The following is a description of a gene set: Mouse Gene Set: chr3F1 studied in species Mus musculus, and this is the list of marker genes: Sh2d2a, Iqgap3, Snord73b, Insrr, Rusc1, Rhbg, Gatad2b, Fbxw7, Mif-ps3, Rps27, Sprr5, Mir7669 (NCBI Gene Id 102465771), Nes, Tsacc, Snord73a, Sprr2d, Lce1m, Gm23850, Bglap2, Thbs3, Gm24481, Gm27811, Sprr2e, Ivl, Gm37116, Gm22577, Adam15, Sprr2a1, Ubqln4, Smg5 (SMG5 nonsense mediated mRNA decay factor), Gm15998, Lce1g, Sprr2b, Gm9790, Lce6a, Pmvk, Gm5849, Pklr, Ints3, Sh3d19, Gm18403, Dpm3 (dolichyl-phosphate mannosyltransferase polypeptide 3), Sprr2a2, Gpatch4, Lrrc71 (leucine rich repeat containing 71), Rab25, Pglyrp3, Lce1d (late cornified envelope 1D), Krtcap2, Paqr6, 4930511M18Rik, 1700036G14Rik, Gm25820, Khdc4, Gm9023, Lelp1, Mnd1, Gm24403, Bcan, Lce1h, Crtc2, Zbtb7b, Isg20l2, S100a5, 1500004A13Rik, S100a1, Lce1b, Gm23464, Rit1, Cct3, Aqp10-ps, Mtx1, Gm3764, 4632404H12Rik, Crnn, Ubap2l, Entrep3, Gm5284, Loricrin (NCBI Gene Id 99536), Gm23376, Trim46, Ssr2, Mir3093, Lce1l, Mex3a, Gm10253, Lce1k, S100a4, Gm19739, Gm36981, Prr9, Fcrl1, Bglap3, Sprr2g, S100a7a, Sprr2h, AW047730, S100a9, Fhip1a, She, Sprr1a, Lce1e, Creb3l4, Gm21956, Gm23054 (NCBI Gene Id 115489857), Sema4a, Gm15535, 4930565D16Rik, Fdps, Adrm1b, Sprr2f, Pygo2, Gba1, Cd5l, Kplce, Pear1, Gm7166, Sprr2i, Mir1905, Slc50a1, Gm24185, Gm10705, Ash1l, Gatb, S100a7l2, Dclk2, Prcc, Gm5979, Lce1f, Flad1, Mir92b, Gm42579, Tmem154, Etv3l, Glmp, Hdgf, S100a2, Gm5850, Crct1, Mettl25b, Gm3788, Lce1a2 (NCBI Gene Id 73722), Arhgef2, Rpl13-ps4, S100a16, Prss48, Crabp2, S100a13, Slc27a3, Gm35439, Etv3, S100a6, Gm15417, Kcnn3, 2210017I01Rik, Slc39a1, Lce1j, Arhgef11, Mir7011, Ilf2, Tpm3, Lce3c, Mab21l2, Dap3, Fcrl5, Lce1a1, Gm3745, Gm19439, Gm29704, Efna4, Hax1, Gm6525, Gm16069, Gm24608, Sprr2j-ps, Rab13 (RAB13, member RAS oncogene family), Gm6821, Lamtor2, Nup210l, Dennd4b (NCBI Gene Id 229541), Dcst2, Ntrk1, Scamp3, S100a8, Gm35013, Lenep, Fcrl2 (NCBI Gene Id 80891), Npr1, Slc25a44, Snapin, AI849053, Ttc24, Sprr2c-ps, Lce3e, Gm8969, Gm26343, 4930537H20Rik, Tdpoz8, Pglyrp4, Jtb, Rtraf-ps, Sprr1b, Pbxip1, 4731419I09Rik, Efna1, S100a3, Lmna, 4933425M03Rik, Tigd4, Gm5851, Sprr2k, Chrnb2, Mrpl24, Kirrel1, Mir190b, 5830417I10Rik, 4933434E20Rik, Rps3a1, Gm25188, Gm25127, Cfap141, Atp8b2, Syt11, Gm8813, Lce1c, Gm20652, Gm19710, Il6ra, Naxe, Pmf1, Glt28d2, Smcp, Gon4l, Lrba, Arfip1, Mir7012, 1700113A16Rik, Sprr3, Msto1, Muc1, Clk2, Shc1, Gm4202 (NCBI Gene Id 100418460), Gm24472, Adar, 4930529C04Rik, Gm25167, Gm23723, Cd1d2, Rxfp4, Sprr2a3, Ube2q1, Lce3d, Tmem79, Lce3a, Bglap, Gm42814, Mef2d, Gm23025, Gm8869, Gm24593, Trim2, Tmem131l, Lce3f (late cornified envelope 3F), Gm25039, S100a14, Gm24046, Lce3b, Kprp, Chtop, Cd1d1, Gm22935, Mir466k, Cks1b, Efna3, Hapln2, Sprr4, Fhdc1, Gm37361, Lce1i, Hcn3, Dcst1, Mir9-1